The following is a description of a gene set: The chemical reactions and pathways resulting in the formation of reactive oxygen species, any molecules or ions formed by the incomplete one-electron reduction of oxygen. studied in species Homo sapiens Human Gene Set: GOBP_REACTIVE_OXYGEN_SPECIES_BIOSYNTHETIC_PROCESS, and this is the list of marker genes: MIR21, MIR675 (NCBI Gene Id 102724852), ZNF205, DUOX1, FAS, MPV17L, LCN2, FYN, CCN6, GRIN1, MIR181A2, DUOXA1, CYP1A2, CYBA, ABCD1, ACOX1, LIPA, STAT3, RAB27A, MPO, TRAP1, PLCG2, ABCB7, SNCA, PIKFYVE, DUOXA2, CD36, ABCD2, PRKN, CLCN3, LETMD1, MIR24-1, UCP1, NDUFC2, RHOA, PARK7, SLC25A33, CYBB, CFLAR, SLC18A2, SPHK2, INAVA, ADCY10, PPARA (NCBI Gene Id 84730), FOXO3, PAGE4, TLR6, ADGRB1, MIR590, NCF1, SOD2, GBF1, CYP1A1, INS, HVCN1, ABCC9, SLC5A3, SOD1 (NCBI Gene Id 6647), ARG2, TLR4, NOX4, DUOX2, ALOX5, MAOB